The following is a description of a gene set: from publication Chen Y, Wang X (PMID 31504780) Human Gene Set: MIR3663_3P studied in species Homo sapiens Genes predicted to be targets of miRBase v22 microRNA hsa-miR-3663-3p in miRDB v6.0 with MirTarget v4 prediction scores > 80 (high confidence targets)., and this is the list of marker genes: ZFYVE26, SIPA1L2, LTBR, DTX4, MSANTD3-TMEFF1, P3H4, BMF, SLC7A6, R3HDM4, SEC24D, DNMT3B, RGS4, SH3BP5L, OXR1, RNF138, SNX24, DLG5, ZKSCAN4, COL4A4 (NCBI Gene Id 1286), CDKN1A, KCTD15 (NCBI Gene Id 79047), ZNF783, CMPK1, OSBPL11, LDLRAD3, ZCCHC3, C1QL4, PLP1, TET2, CTDSPL2, SEPSECS, PLEKHF2, AHNAK, TKT, CDC42SE1, ITPRIP, PAN3, EXOC4, MMP15, CLEC1A, RAPH1, GID4, USP37 (ubiquitin specific peptidase 37), DCAF7, RASSF4, TRAF3, PGM3, LRFN4, TOMM20, NNAT, CREBRF, MATCAP1, ADA, B3GNT5, MRO, PRICKLE2, P2RY6, PATZ1, FRMD4B, AP1G1, VIPAS39, SH3GL1, MLXIP, GXYLT2 (NCBI Gene Id 732216), TMTC3, CA3, ZNF516, HAPSTR1, YPEL2, SLC25A13, COL22A1, ATRN, TMEM117, ZNF507, RIMKLB, LAMTOR1, UNK, GRPEL2, CHL1, DUSP4, FKBP1B, MAML1, PPM1E, PPP1R13B, GNB4, SLC25A53, RNF214, FAM124A, TUBB2A, MTX3, MICB, AIMP2, NFKB1 (NCBI Gene Id 4790), ADAMTS2, PTPN1, SNRK, SIAH3, TBC1D7, CCDC8, POLE3, RAB5A, KDM6B, LENG9, SETDB2, TRPV4, NID1, TMEM169, C1QTNF6, ZBTB10 (zinc finger and BTB domain containing 10), COL27A1, SPPL2B, VSIG1, TMEFF1, FREM2, CDC42, FAM13B, CD151, MINAR1, THAP8 (NCBI Gene Id 199745), SET, SLC26A11, CNPY4, TRIM37, CCDC186, NIPAL4, MYORG, AK1, ZFP91, POGLUT2, CHSY1, COL11A1, STRN3, RUSC2, TMEM151B, SLC16A1, CACNA2D2, KLHL18, ETV4, CASP2, INO80D, ANK3, ALS2, HAPSTR2, CRISPLD2